The following is a description of a gene set: Reactome Pathway: Threonine catabolism studied in species Mus musculus electronically inferred by orthology from the curated human pathway part of: Metabolism of amino acids and derivatives This event has been computationally inferred from an event that has been demonstrated in another species.<p>The inference is based on the homology mapping from PANTHER. Briefly, reactions for which all involved PhysicalEntities (in input, output and catalyst) have a mapped orthologue/paralogue (for complexes at least 75% of components must have a mapping) are inferred to the other species., and this is the list of marker genes: Sds, Rida